Given this list of marker genes CALM1, PLAT, HDAC4, IGF1R, AKT1, COL10A1, BMP7 (NCBI Gene Id 655), CDKN1C, GLI3, FGFR1, THRA, MMP9, BMP6, TGFB2, MMP13 (NCBI Gene Id 4322), FGFR3, SLC38A2, CAB39, ADAMTS4, IGF1, DDR2, PTHLH, IGF2, SERPINH1, GH1, CST5, PRKACA, TIMP3, HMGCS1, ACAN, MGP, FGF18, VEGFA, COL2A1, SOX5, IHH, RUNX3, SOX6, FGF2, ADAMTS5, NKX3-2, FRZB, CHST11, SPP1, SOX9, STAT1, CTSV, IFT88, ADAMTS1 (NCBI Gene Id 9510), SCIN, TGFB1, GHR (growth hormone receptor), RUNX2, PTH1R, ENPP1, STAT5B, PTCH1, KIF3A, ALPL, MEF2C, BMPR1A, PLAU, PTH, here is a description of the gene set: species: Homo sapiens Endochondral ossification Human Gene Set: WP_ENDOCHONDRAL_OSSIFICATION